Given this list of marker genes PRDM4, HDAC3, HDAC1, NGFR, NGF, HDAC2, here is a description of the gene set: part of: p75 NTR receptor-mediated signalling studied in species Homo sapiens Reactome Pathway: p75NTR negatively regulates cell cycle via SC1 SC1 (Schwann Cell factor 1; also called PR domain zinc finger protein 4, PRDM4) interacts with an NGF:p75NTR complex and signals cell cycle arrest by regulating the levels of cyclin E.